The following is a description of a gene set: Human Gene Set: GOBP_FATTY_ACYL_COA_CATABOLIC_PROCESS The chemical reactions and pathways resulting in the breakdown of a fatty-acyl-CoA, any derivative of coenzyme A in which the sulfhydryl group is in thiolester linkage with a fatty-acyl group. studied in species Homo sapiens, and this is the list of marker genes: NUDT8, FITM2, NUDT19, ACOT7, ABCD1, NUDT7